The following is a description of a gene set: During cellular differentiation and development, it is recognized that many complex molecular mechanisms as well as precise patterns of differentially expressed genes occur in directing precursor cells toward a given lineage. Using microarray-based technology, we examined gene expression across the course of 3T3-L1 adipocyte differentiation. Total cellular RNA was isolated at times 0, 2, 8, 16, 24, 48, and 96 h following treatment with either standard hormonal inducers of differentiation; insulin, dexamethasone, isobutylmethylxanthine (IDX), or IDX plus trichostatin A (TsA), a histone deacetylase inhibitor and potent adipogenic inhibitor. cRNA was synthesized from cellular RNA and hybridized to high density Affymetrix MG_U74Av2 microarray gene chips containing 12,488 cDNA/Expressed Sequence Tags (ESTs) probe sets. From the IDX-only treated cells, all probe sets that were either unchanged or differentially expressed less than 2-fold throughout differentiation with respect to time 0 preadipocytes were excluded from further analyses. This selection resulted in a net of 1686 transcripts, 859 were increased in expression, and 827 were decreased in expression at least 2-fold across differentiation. To focus in on genes that were more specific to differentiation, the same analysis was performed on IDX plus TsA-treated non-differentiating cells and all probe sets from the IDX-only group that exhibited similar expression profiles in the non-differentiating TsA-treated group were excluded leaving a total of 1016 transcripts that were regulated only under differentiating conditions. Six hundred and thirty-six of these transcripts were elevated at least 2-fold and 380 exhibited a decrease in expression relative to time 0 preadipocytes. This group of genes was further analyzed using hierarchical clustering and self-organizing maps and resulted in the identification of numerous genes not previously known to be regulated during adipocyte differentiation. Many of these genes may well represent novel adipogenic mediators and markers of adipogenesis. Human Gene Set: BURTON_ADIPOGENESIS_4 species: Mus musculus Progressively up-regulated from 8-48 h during differentiation of 3T3-L1 cells (fibroblast) into adipocytes. from publication Burton GR, Nagarajan R, Peterson CA, McGehee RE Jr (PMID 15033539), and this is the list of marker genes: H2AX (NCBI Gene Id 3014), IFI16, EIF2B1, NHP2, IGFBP4, PPP2R1B, ZNF385A, FKBP4, GLUL, EMC8, PLXND1, LDHA, COL18A1, BCL6, UCHL5, SREBF1, ATP6V1F, SNRPA1, ADIPOR2, CCT3, RHOU, NSUN2, ZNF706, PPM1G, DAXX, CMC2 (C-X9-C motif containing 2), ST3GAL4, ENTPD6, ANGPTL4, NOP2, MRPS12, POLE4, RCL1, COL4A2, DDX51, CSE1L, DPEP1, ABCF2, EPHB4, COL6A1, COL6A2, AGTR2, H19, IDH3A, LSM3, ANXA8L1